The following is a description of a gene set: We demonstrate that the G protein Gi3 is the cellular target of the adenosine A3 receptor (A3R). By using a cell permeable peptide comprising the C-terminal end of Gαi3 fused to an importation sequence (ALL1) as a selective inhibitor of Gi3 signaling, we show that by coupling to Gi3, the A3R stimulates multiple signaling pathways in human mast cells, leading to upregulation of cytokines, chemokines and growth factors.Following contact with activated T cell membranes, endogenous adenosine binds to and activates the A3R, resulting in Gi3-mediated signaling. Specifically, the majority of ERK1/2 signaling initiated by contact with activated T cell membranes, is mediated by Gi3, giving rise to ALL1-inhibitable cellular responses. These results unveil the physiological GPCR that couples to Gi3 and establish the important role played by this G-protein in inflammatory conditions that involve adenosine-activated mast cells. We used microarrays to detail the effect of ALL1 on gene expression of HMC-1 cells activated directly by the A3 receptor, or by contact with activated T cell membranes. Genes up-regulated in HMC-1 (mast leukemia) cells incubated with the peptide ALL1 versus those then stimulated by T cell membranes. studied in species Homo sapiens Human Gene Set: GSE19888_ADENOSINE_A3R_INH_VS_INH_PRETREAT_AND_ACT_WITH_TCELL_MEMBRANES_MAST_CELL_UP from publication Baram D, Dekel O, Mekori YA, Sagi-Eisenberg R (PMID 20190146), and this is the list of marker genes: PIGN, FADS1, STAT2, POFUT2, CAMK2N1, CASP1, TMEM87B, FAT4, MYH10, FNDC3A, EVI2B, YIPF4, ITGBL1, C5orf34, CASP4, RAD51D, TMEM263, NUPR1, SSH1, PXYLP1, ATPSCKMT, CARS2 (cysteinyl-tRNA synthetase 2, mitochondrial), PARK7, OGFOD3, RNASE6 (ribonuclease A family member 6), ELOA, SNAPC1, MANBA, PARP12, RAB32, BCO2, IRF1, DENND10 (DENN domain containing 10), LARS2, HLA-DRA, PIGL, TAGAP, NDUFA10, FLT4, PPT1 (palmitoyl-protein thioesterase 1), EXT1, TM7SF3, USP36, SIX1, TCEAL1 (transcription elongation factor A like 1), GBP6, IFNAR1, FAM220A, NIPSNAP2, LRRC57, DAPK2, GBP4, C5orf22, PKIG, CFAP96, H2BC18, PAQR7, H2BC13, CCDC88A, GPD1L, MINDY2, DUBR, USP21, FUT11, C11orf52, NRP1, AKAP12, RNF213, RSAD2, DTX3L, IFI44L, MAPRE1, HOXD8, APLNR, GBP7, COLEC12, OTULIN, SNX24, GUCA1A, TM7SF2, EFR3A, IFFO1, GSTM1, CA5B, CXCL9, IRGM, PARP14, DHRS7, P4HTM, OAS2, CLMP, CYB5B, IFI27L2, L3HYPDH, REEP6, RHOBTB3, WDFY1, CILP, TRDN, NDST1, ISG15, CYP2B6, CCDC61, PDGFD, PDXDC1, TNMD, P2RY13, FKBP14, SMIM20, MAGOHB, DECR1, ELK3, RTP4, BAIAP2L1, GUF1, CYP2E1, TBC1D4, AGMO, DNAJC10, TEK, HCK, NRCAM, IDH3G, AMACR, MIR99AHG, CEP164, GALC, THUMPD1 (THUMP domain containing 1), KAZALD1, CD209, CDK14, RHBDL2, ENPEP, CCSER2 (coiled-coil serine rich protein 2), HELZ, TGDS, SHISA4, IRF8, PRELID2, FAM149A, EIF2AK3, FNDC1, PDPN, MTHFR, PSMG4, IBTK, SQOR, IFIT1B, CD93, TOR3A, MCCC1, GNS, TXNDC15, ARL6IP1, CERS5, UQCC3 (NCBI Gene Id 790955), RAI2, SMC6, CAND2, OAS1, MCAT, DESI2, COCH, SAMD9L, TRIM26, SERINC3, AKT3, SAMSN1, FAH, DCTN5 (dynactin subunit 5), TNNT1, CPQ, FLI1, PDGFRL, RIGI, CMBL, LMOD3, ZBED3, RXYLT1, OGFRL1, KLHL13, ZFHX3, ARL8A, FERMT2, HJURP, NNT, ATP8A1, IL15, LGALS4, DYNLT2B, ZBTB20, MAD2L2, ELF2, ZNF25, MS4A6A, SLC2A9, DOLK, DNASE1L1, USP18, SERPINB4